The following is a description of a gene set: Human Gene Set: GSE18893_CTRL_VS_TNF_TREATED_TREG_24H_DN from publication Nagar M, Jacob-Hirsch J, Vernitsky H, Berkun Y, Ben-Horin S, Amariglio N, Bank I, Kloog Y, Rechavi G, Goldstein I (PMID 20181891) studied in species Homo sapiens Genes down-regulated in T reg cells: 2h versus 24h medium treatment. Here we show that tumor necrosis factor (TNF) induced in human T-regulatory cells (Treg), as compared to conventional T cells (Tcon), a transcription program highly enriched for typical NF-κB target genes, such as: the cytokines LTA and TNF; the TNF-receptor super family members FAS, 4-1BB and OX-40; various anti-apoptotic genes; and other important immune-response genes. As an initial approach to examine the cellular program induced by TNF in Tregs versus Tcon cells, we employed microarray gene expression analysis at 2 and 24 hrs following TNF treatment., and this is the list of marker genes: OSBPL3, PARVB, TAF3, SYAP1, TREML4, MBNL2, ELL, CAMP, C11orf71, ITGB4, AP2A2, RNF168, ZDHHC24, NOP53, ERN1, RDM1, SFT2D3, LAMC2, ABTB1, NBAS, TYK2, ZNF496, CASP4, LDLR, CLUAP1, SFT2D1, PRKCD (protein kinase C delta), FAM110A (family with sequence similarity 110 member A), HSD17B4, PRR5L, SLC7A4, GUCY1A1, SOWAHC, ZNF180, ZSCAN22 (zinc finger and SCAN domain containing 22), DCP1B, LETMD1, RNASE6, NEDD9, ANLN, FHIP1B, DPM1, PCBD2, C12orf57, IL9R, ZNF445, NUDT7, GSTA3, PBX1, PDPR, SPATA1, BLTP1, PTPN22, HAS3, CCM2, HDAC4, TNNI3, HOXB6, PIP4P1, WWOX, MPC1, CALB1, POU4F1, NAPG, AFF3, MMS22L, B3GNT8, GNAS, CNTLN, MTCP1, ZCCHC3, ANTKMT, MMRN1, ZFC3H1, NUSAP1, GUCD1 (NCBI Gene Id 83606), PGC, PF4, KRCC1, CAVIN2, AREL1, ALS2CL, GRB14, ADNP, SLC6A9, CENPJ, TTC17, CRTC3, VWA5A, UBE2T (ubiquitin conjugating enzyme E2 T), PLPP3, FBXO7, BPIFA1, FOXA2, RLF, PAM, H2BC13, SLC9A9, UCP2, SLC12A6, TSPOAP1, SAXO5, ARFGAP2 (NCBI Gene Id 84364), TCTA, EPM2AIP1, ALG2, RMND5B, WDR26, CCDC181, CCL5, ASNSD1, SIPA1L3, NIBAN1, EXOC4, ADAM8, CHI3L1, HLA-DOA, SACM1L, CREBRF, REEP5, CCN4, RNF44, GALNT18, SLFN12, INTS6, KRT28, SERHL2, ASB3, NCOA7, IRGQ, SMC1A, KLF7, GRAMD1A, MED10, MSMO1, LRTM2, PPIG, DGKG, VPS28, CEP20, ANXA7, CNBD2, HAPSTR1, SLPI, SRSF12, BAZ2B, AXL, ZSWIM8, RABGAP1L, PDE4DIP, ELK4, CLEC10A, ZMYM5, CSTA, SPRYD3, RUSC2, CLTC, SYNJ1, SHCBP1L, B2M, NDUFA13, SURF1, NUB1, LCP1, ELMOD3, HECA, CIB2, SLFN12L, ABCA7, DAAM1, CHAD (NCBI Gene Id 1101), ZFAND4, STARD3, LZTFL1, HPS5, DMC1, PDZRN4, SREBF2, P2RY13, DOK1, GRPR, DMAC2L, CALCOCO1, ATL1, ISG15, METTL25B, H1-2, KMT2C, ATRX, GIMAP4, SLC25A28, BAHD1, HOOK3, TAFAZZIN, TRAF3IP3, KCTD18, ZBTB11-AS1, ZFYVE27, EID1, ARL3